Given this list of marker genes RAB31, BMP6, PGRMC1, MDFIC (NCBI Gene Id 29969), MX2, NEUROD1, FXYD6P3, SNX12, SPACA3, CBLB, GPR68, SOD1, ATPSCKMT, MIR424, METTL21C, RAB3D, CETP, SLC35F6, PKDCC, RAB4A, PAX8, RUBCN, TMEM97, GNB5, RIN3, SPG7, SLC31A2, RAP1GDS1, GCK, ANGPT1, NCBP2, CXCL11, TLR9, RAB27B, DNAJA1, SLC25A22, CD63, SV2B, TMEM38B, TOR1A, ABCA3, ARC, TUNAR, RGS2, PTPN11, CA2, MICAL1, BLK, ARHGDIA, NPY2R, UNC119, STX1B, HAP1, PDZK1 (NCBI Gene Id 96133), GAL (galanin and GMAP prepropeptide), SLC11A1, ENSA, UBE2G2, HTR1B, RANGAP1, SLC1A2, CLDN3, GHRHR (NCBI Gene Id 2692), CALM1, SLC7A5, NKAIN2, GRP, DOC2A, CELA2A, PLD1, HMGB1, APOA4, RHOQ, IL1RAPL1, RHBDF2, NR1H4, KCNJ16, KCNS2, TMEM38A, CD160, MIR186, UTRN, SYN1, ACTB, BCAP31, OPN3, FCN2, TNK2, VPS35, PPFIA2, PPP1CC, PTPN3, ANKRD13D, MDM2, PER2, FXYD2, PRAP1, RASL10B, ASIC2, IL12A, ATXN2, ZFYVE16, BDKRB1, SLC38A3, EDN3, PTPRC, GPC3, FERMT1, CPSF6, HLA-F, RPH3AL, KCNIP3 (NCBI Gene Id 30818), IL11, RAB3A, RFX3, MIR766, VAC14, ARF1, TPR, FMR1, ACE2, CTNND1, PFN2, SMPD3, ADRB2, MIR145, PRRT1, CEBPB, EDEM2, PTPRN, GHSR, ADTRP, SNAP25, RALA, NIPSNAP2, PPP3R2, TM7SF3, KCNA5, SYT13, CXCL9 (NCBI Gene Id 4283), ANKRD13A, IER3IP1, TNFSF11, INHBA, POMC, HMGA2, ORAI1, UCP2, AKAP8L, MIR495, NPY, LRPAP1, FUT11, HCRT, ZP3, RIMS4, MCTP2, KCNG1, SLN, LCN2, ADORA3, IRS1, SIRT4, SRC, NR1H3, KCNJ14, CABP1, PICK1, DENND10, NUMB, EP300, PARK7, ABCA8, SV2C, ATP9A, P2RY2, MYOM1, SORBS1, INHBB, HTT, ATP8A2, ABCA2, LILRA5, CHRM1, FFAR1, CASK, NOS2, GSTO1, CCN3 (cellular communication network factor 3), CACNG8, PCM1, TRPM5, ENY2, KCNA2 (potassium voltage-gated channel subfamily A member 2), DRD4, PLA2G5, PTPN1, MIR146A, RAC1, CACNA1B, CDH1, FLOT1, UNC13D, SERPINE2, PLPP4, GFAP, JUP, PTPRJ, TMEM132A, BORCS5, AGT, SLC8A1, TERT, SLC7A11, FRAT1, NFKB1, NKX2-5, SLC17A8, YJEFN3, MIR302A, IL4, DKK1, RAP1BL, CHP1, DHRS7C, RAP1GAP, MIR128-1, BCL2L1, SYT15, TREM2, XRCC4, VPS18, RAB9A, PCNT, DENND5B, CHMP3, MBTPS1, WNK3, TACR1, CASP3, SLC26A6, SCN2B, RAB3B, HCLS1, KHDRBS1, ZC3H12A, SELENOK, ERFE, MIR199B, SNCA, MAPK1, DMPK, ANK2, STAC2, TBC1D4, CYP19A1, NMU, THOC2, AP2A1, MUL1, ZNRF2, KIF5B, CCL19, VAMP2, LYN, CORO1A, CLDN2, ZNRF1, ABCA7, PHB2, TCAF2, DOC2B, RAB11B, GCLC, LILRA2, RUFY3, PRKAA1, SCFD1, APLN (apelin), DLL1, C1QTNF1, DCANP1, DISP3, SNAP91, GRIN3B, PTEN, JAK2, TRIM27, DERL2, CDH13, CALHM1, ICE1, TMED10, SMO, DDX39A, GABBR1, PACSIN2, SLC30A8, MPC2, SCRN1, CBLL1, CTSS, OAS2, IL1A, MIR183, ADCY8, MIR93, ACSL1, SIRT1, IPO5, SELENOS, USP46, CCL3, ASPH, MIR148A, WNK2, HAMP, STON1, AHNAK, STAC, RAN, PKIG, APOC1 (apolipoprotein C1), P2RY6, CNKSR3, MPV17L, P2RX1, FGA, ADCYAP1R1, CACNG2, SLC18A3, GNAS, FAM3D, CEP290, CCL21, STRIT1 (small transmembrane regulator of ion transport 1), KDM5B, C3, FCGR2A, SIVA1, ACHE, BMP2, ALOX12B, SSTR5, RCVRN, PKIA, PARD6A, PLAA, OAZ1, XCL1, SDC1, SCN4B, GAS1, SPHK1, GPM6B, PROM2, LGALS3, APELA, EMD, SRI, RIT2, ANKRD27, MAP2 (microtubule associated protein 2), STK11, HDAC3, ARL6IP1, CREB3, LACRT, CDH2, ABCA1, DPP6, TRIAP1, PHPT1, HADH, RAB5A, SERGEF, SCAMP5, SURF4, SELENON, TRPA1, APPL2, PPP3CB, EI24, SMPD1, TFR2, RSC1A1, REM1, RBM10, STXBP2, SGK2, RAB27A, FGF21 (NCBI Gene Id 26291), MIR133A1, CACNB3, G6PC2, JPH2, MIR20A, SPG11, C1QTNF12, HCAR2, KCNE2, MYB, SEPTIN4, CAMK2G, SCRIB, NF2, MIR199A1 (microRNA 199a-1), CPT1A, PRAM1, ERGIC3, GPD1L, ATP2C2, EFHB, RIC1, RAB11A, PLA2G1B, SLC16A1, FBXO45, SLC26A5, HCK, NNAT (neuronatin), POU4F2, SLC35D3, AZU1, BGLAP, PSMD9, TRIM58 (tripartite motif containing 58), RAB5B (NCBI Gene Id 5869), DYNC1H1, RIMS3, GIP, EHD1, ARL6IP5, GRIA1, DNM1L, VPS4A, NLGN2, SLAMF1, CD14 (NCBI Gene Id 929), FGF23, VEGFA, ABCA12, APOE, PFKM, LAMTOR1, AVP, AP2B1, PPP3R1, CERS1, NR1H2, NRP1, KLF15, CACNA2D1, SHH, SYT6, GNAO1, SNAPIN, STAP1, TRPV2, WNT5A, ABCG1, G6PD, MIR206, PDX1, CD2AP, WFS1, PTK2B, BAX, PACSIN1 (NCBI Gene Id 57564), SLC2A2, FCN1, LILRB1, PTPN23, C4B, CHRNB2, AKAP6, TGFB2, GAS6, LPAR1, MIR301B, SYT2, SLC25A31, RYR2, FABP5, MTMR2, MIR29B1, FCER1G, CCR2, PLA2G6, SMAD4, SELENOT, ANP32B, KCNIP4, DNAJC1, TMBIM6, PYCARD, GJA1, PDGFB, LYAR, SDHD, DYSF, GRK2, UBQLN1, IL2RG, WDR44, SYTL4, KIF20B (kinesin family member 20B), MIR30D, MYLK, PICALM, APOC2, CTTNBP2NL, GHRH, TMC1, KCNQ1, ECRG4, IL15RA, P2RX7, GRIN2A, AP2M1, RABEP1, MAGI2, RSPO1, TPCN2, RIOK2, TGM2, ATP2C1, GPR151, ADCYAP1 (adenylate cyclase activating polypeptide 1), TTC39B, MICU3, CFP, NOS3, C1QTNF3, FKBP1A, NEUROG1, TRH, TMEM53, RAB33B, IRS2, SCN3B, ACSL5, UMOD, CDK16, GNAI2, F2RL2, IL1B, TSC2, DLG4, PLD2, GSG1L, RIMS1, ITGAM, BAG3, SYT10, TCF7L2, ATP2A2, GCC2, FFAR2, ADORA2B, GSK3B, AAK1, MEF2A, GJA5, KCNB1, CD19, CNIH2, CADPS2, PGAP1, WDR41, HYAL3, ANK3, IL13, ADRA2C, GRM7, CCL2, OS9, TSPO, STXBP3 (syntaxin binding protein 3), SLC30A6, EPHA5, IFNG, REPIN1 (NCBI Gene Id 96712), PLLP, P2RY1, MIR758, RAB11FIP1, TAC1, PLA2G4A, OSBPL8, ITGB3, SARAF, MYRIP, PRKN, ABAT, KCNK9, SLC51B, CRHBP (NCBI Gene Id 1393), OCLN, KCNAB3, DBI, OSBP, CD300A, STC2, MIR185, SLC4A8, IL13RA2 (interleukin 13 receptor subunit alpha 2), LYPLAL1, MIR205, ACSL4 (NCBI Gene Id 4426), CD84, TSG101, RBP4, MIR144, PRNP, DNAJC6, CHMP6, AMIGO1, SVIP, PPIA, ERBB3, ASIC1, CD36, CDH3, LIF, TRPV6 (NCBI Gene Id 55503), SNX4, ABCC8, SYBU, NSF, HIP1R, ATP1B2, CHRNA6, PRKCG, CLU, BRSK2, HEPH, MIR107, ATG5, SLC12A2, AFG3L2, CCDC32, CHGA, RHBDD1, ARPC3, COLEC10, HRC, TULP1, TRPM4, PDE4B, SNCAIP, FGR, FGF20, FERRY3, MAP2K1, SIRT7, TGFB1, MIR129-1, PACSIN3, PID1, SLC43A2, ARHGAP1, CBL, BMP8A, MIR143, TRPV3, MIR30C1, VAMP8, CARTPT, HK2, GAPVD1, USP7, CD4, ARRB2, PPP1R12A, BMAL1, OPHN1, CLDN19, PASK, RAB5C, ATP2B4, SYT8, F2RL3, XBP1, PPP3CA, TTN, CRY1, JAGN1, SOX11, PIK3CG, SNX6, TFF2, LRRTM2, ARFIP1, IDH2, SLC30A3, NF1, SDC4, GGCX, IL16, CD151, ITSN1, KCNS1, EFNB2, MIDN, ZPR1, ADA, GIT1, CACNG4, FCGR1A, FKBP1B, FXYD1, CHRNA3, CYP4F2, GNB2, PTCH1, RAB25, S100A8, ERP29, ABCG4 (NCBI Gene Id 64137), EDNRA, ZBED6, NOTCH1, BTBD9, ASPSCR1, IL6, FEZ1, MEF2C, PRKCD, HIP1, SYT17, B2M, AKT1, STXBP4, AAAS, SYT5, LRAT, KCNIP2, DMAP1, COLEC11, CLASP1, STC1, P2RY12, RAB37, KCNF1, PLN, MIB1, NUP214, TESC, LRRK2, BAD, SYK, BEST1, RGCC, CTDSPL2, NR1D1, NKX6-1, AACS, ANXA1, LDLRAP1, CRH, SEPTIN2, SDCBP, PTPRN2, GDNF, MIR133B (microRNA 133b), SLMAP, CTNNB1, OR51E2, ARHGEF5, TBC1D5, SPX, SERPINE1, CACNG5, SCN1B, SEC24A, SLC25A5, RXRA, FXYD4, ADAM9, HOMER3, APOA2, RFX6, NGF, YOD1, GPER1, USH1G, PRKCA, CALCA, OAZ2, CYP4A11, P2RX4, BSG, AQP1, NDFIP1, GATA1, SYT3, CHP2, PCK2 (NCBI Gene Id 5106), LRRC26, NPFF, FXYD7, RAB21, SGK1, GLI3, CFTR, PLCG2, DRD2 (dopamine receptor D2), POFUT2, STX18, ANO6, BEST3, PFKFB2, CALM2, SNF8, PPM1A, SERP1, ATP1A2, GPLD1, STK39, ANXA13, FOXL2, CDK1 (cyclin dependent kinase 1), NKAIN1, NEDD4, UCN, CD47, UBR5, NECAB2, TMEM30B, COX17, MIR26A1, FCGR2B, SLC43A1, UBQLN2 (NCBI Gene Id 29978), SIRPB1, CRBN, APP, FRMD4A, RIPOR1, B3GAT3, KCNJ3, NUMA1, DERL3, CEP131 (centrosomal protein 131), ILDR1, SFTPD, MIR130B, HOMER1, LRP5, MIR223, ALOX5, CCL5, NPR1, CLIP3, PXK, NHERF1, CACNB4 (calcium voltage-gated channel auxiliary subunit beta 4), FGF12, JPH3, CACNG3, LPAR3, CLDN10, NDEL1, TUB, ITGB2, SPHK2 (sphingosine kinase 2), ABCB4, IL12B, PRKD1, CACNG1, CAMK1, CWH43, P2RX3, HSP90AA1, TGFB3, NSUN2, TRPC3, CXCL10, F2R, PRKAR1A (protein kinase cAMP-dependent type I regulatory subunit alpha), EPO, MIR212, TCIRG1, FIS1, PIK3R1, SCARB1, EPB41, LEP, PRRT2, MYO18A (NCBI Gene Id 9799), ATP1B3, OXCT1, KCNJ5, VEGFC, EHD4, NEDD4L, INPP5F, HES1, SAR1B, PDE8B (NCBI Gene Id 8622), UCN3, COMMD1, SIK1, VPS4B, MLXIPL, OSR1, MKLN1, CACNB2, DHX9, CLEC7A, RAB7A, TNFRSF1A, REEP6, PRSS8 (serine protease 8), MIR208B, SCP2, HTR2C, SEPTIN8, KCNJ6, NMB, MIF, CLASP2 (cytoplasmic linker associated protein 2), SGIP1, YWHAH (NCBI Gene Id 7533), CAV3, CACNA1F, SMAP1, MIR1-1, ADORA2A, AVPR1A, MBL2, PPARA, MMP9, TMSB4X, APOD, OPRM1, AHI1, GRM2, ZNF205, RHBDF1, KCNJ4 (NCBI Gene Id 3761), VTN, OXT, CACNG7, KCNAB1, WLS, RBM4, HGS, AXL, MIR499A, CHMP2A (NCBI Gene Id 27243), EHD2, EPM2A, GDF9 (NCBI Gene Id 2661), KCNMB4 (NCBI Gene Id 27345), CDC42, HTR1A, AIMP1, PLA2G4E, ATF4, UBASH3B, NEU3, SH3GL3, KCNC2, MIR27A, KCNC1 (potassium voltage-gated channel subfamily C member 1), FHL1, CYP51A1, NKAIN3, MIR34B, PLCB1, STXBP6, LPCAT3, LCP1, STIM2, THY1, LYPLA1, CA7, DAB2, FGFR1, CPLX2, SFN, BICD1, STOM, CAMK2D, PPT1, AP2S1, KCNN2, INS, NPPA, CACNA1D, GRIN1, BSN, GHRL (NCBI Gene Id 51738), DMD, SMCR8, PCSK9, KLRC2 (killer cell lectin like receptor C2), IGF1, WNT7A, NDFIP2, MIR448, KRT20 (NCBI Gene Id 54474), TLR2, EFNA5, HMGCR, TM9SF4, OXSR1, MIR9-1 (NCBI Gene Id 407046), SCIN, EDN1, BOK, TMEM30A, ROCK1, ABL1, BCR, AHCYL1, ALOX15, AZIN1, STAC3, NPY5R, APOA5, LEPR, MIR328, KCNJ8, FCGR1BP, MAP2K2 (mitogen-activated protein kinase kinase 2), SCT, GPR35, PINK1, MINK1, OPRK1 (NCBI Gene Id 4986), ITLN1, CRYZL2P-SEC16B, ERLEC1, CORIN, OAZ3, CD38, WNT3A, HSPA8, SUSD4, PLTP, CALM3, MIR34A, WWC1, EXPH5, ARAP1, GRIPAP1, CHRNB4, ACVR1C, ACTN2, RUFY2, ISCU, GRM6, ITGAV, EZR, P2RX5, PLCG1, KCNJ2, FASLG, UQCC2, F2, FFAR4, WNK4, SNTA1, DLG1, ITGA2, NADK, XPO1, RAB29, TCAF1, FGG, VDAC1, PSEN2, ERC2, PON1, IL15, EPHA3, BMP2K, FABP3, REST, KEL, PPARG, OTOF, P2RX2, RAP1A, NTF3, YWHAE, LRP1, KCNS3, AKAP7, BARD1, DRD1, TNFRSF11A, CLN3, GIPR, MIR873, TFAP2B, NEGR1, SETD2, BAIAP3, RAB4B, DNAJC5, RHBDD3, SLC25A4, TAMALIN, FRAT2, ISL1, ZDHHC2, CD74, RUFY4, CD177, GAB2, STXBP1, SEPTIN1, AZIN2, SLC38A2, FOXO1, STIM1, BCL2, MTNR1B, UBR3, TARDBP, RAPGEF4, LRRTM1, ECT2, TBC1D20, ADORA1, APBB3, FCRL3, NEO1, APOC3, KCNJ15, FURIN, LRSAM1, PLA2G10, CSK, SAA1, RAB23, FCN3, CPLX1, BMP4, PRKG1, EEF2K, TMEM14A, ITGB1, PDCD6IP, SLC34A1, TRPC6, HHEX, CXCL12 (C-X-C motif chemokine ligand 12), XPO4, WDR54, RNF139, SLC17A7, GSTM2, PTGES (prostaglandin E synthase), FYN, ZIC1, ANXA2 (NCBI Gene Id 792), SMAD3, SNX3, CYBA, SP100 (NCBI Gene Id 6672), MIR208A, RUFY1, TMX1, VAMP7, REEP2, CALY, GALR2, NEFH (NCBI Gene Id 4744), PREPL, SNX17, LIPG, MIR92B, CPLX4, ATP13A2 (NCBI Gene Id 63919), SUFU, OSM, ZFAND1, LAMP1, SYT4, TNNC1, TXN, OPRD1, RGS4, DGKD, SLC25A27, NAXE, PEA15 (NCBI Gene Id 8682), HLA-DRB1, EIPR1, SIDT2, KCNG4, PPID, STIMATE, ARHGAP44, VPS28, CD22, MLC1, CREB1, LIME1, PKD2, KCNJ9, MCU, VAMP3, MIR508 (microRNA 508), TRIB3, SYT7, DYNC1LI1, SIRT6, PLA2R1, ABCB1, DGKQ, C4A, PDPK1, RDX (NCBI Gene Id 5962), ACTG1, CDK5R2, CDKN2A, TF, CSPG5, PLA2G3, USE1, PRELID1, MIR19B1, TRDN, RNASEL, TENM1, RNF220, KMO, PRKAG2, YWHAB, ARF6, EPPIN, FUT10, SNX9, AP1G1, SH3TC2, GH1, P3H1, CNN2 (NCBI Gene Id 1265), SORL1, CD300LF, RAB3GAP1, WNK1, FCGR2C, GSK3A, PER1, LETMD1, KLF7, TRIM28, FXYD6, SCN10A, KCNE5, RAB11FIP5, HNF4A, ADCY5, TTC21B, TMF1, GCG, APBB1, RIMS2, CNST, GATA2, GABRE, UFM1, ACTN4, CEACAM1, CNIH3, TSPAN13, ADRA2B, KCNN4, CDK5, CAMK1D, GOLPH3, GNA11, FXYD3, GALR1, CASQ2, FZD9, PFKL, CHRM3, PTH, HPCA, GOLPH3L, IFI27 (interferon alpha inducible protein 27), RAB2B, SNX33, PTGER3, PDGFRB, AKT2, JPH4, MIR103A1, KCNAB2, MSN, PPARD, NR4A3, KCNJ1, PIM3, WASL, OSTN, CLOCK, RINT1, PRKG2, CRY2, TOR2A, BPIFA1, PRKACA, CCR7, DYNLT2B, CHCHD10, RAB26, YIPF5, NFKBIA, PPIF (NCBI Gene Id 10105), SOX4, MIR181B1, SLC6A4 (NCBI Gene Id 6532), SIRPG, ARHGAP8, FGF13, RABGEF1, FER1L5, CHRNA4, SNCG, FES, INPP5K, GPR143, MCHR1, MIR17, DIAPH1, PDCD10, SYNJ2BP, FAM76B, MAP1B, TSPOAP1, NKAIN4, NKX3-1, SLC30A1, PRTN3, ICA1L, ACAA2, DTNBP1, HIF1A (NCBI Gene Id 3091), CHD7, MAPK3, FLNA, FOXA2, MRLN, MIR33A, AKAP5 (NCBI Gene Id 9495), CALR, SPAG5 (NCBI Gene Id 10615), ATP8A1, NFE2L2, CASQ1, GRIN2B, CACNB1, NUP58, FFAR3, PTPN6, PIP4P2, PLS3, ATP5IF1, TIFAB, NOS1AP, OSBPL6, MYH10, PTX3, SPI1, KCNIP1, MCUB, NPVF, LMAN2, KCNG2, STXBP5 (syntaxin binding protein 5, NCBI Gene Id 134957), ATP2B1, ARFGAP1, ANKFY1, NDRG4 (NDRG family member 4), GPR27, ANKRD1, KCNK16, CD33, MIR613, CCL4, KCNJ12, PPM1F, NPSR1, PTPRM, VAMP4, SEMG1, TNFRSF1B, GNAI1, SYNGR3, SYT1, NPPB (natriuretic peptide B), ITPR1, ALKBH5, SCG5, NDUFAF2, CLIC2, SPP1, CLTCL1, SLC9B2, NUS1, PRR5L, PLK3, PSEN1, ATP8B1, PRKCI, NCDN, CAB39, ZDHHC7, EEPD1, TRPC1, IL4R, ANXA2P2, ENPP1, HFE, IL2RB, MCTP1, EGF, LRRC52, CPLANE2, NTSR1, REEP5, NR0B2, CAMK2A, DAPK1, UHMK1, HOMER2, GRB10, ARPP19, DPH3 (NCBI Gene Id 285381), APOA1, AGTR1, RAB8B, RETN, STX1A, UBAC2 (NCBI Gene Id 94902), KCNG3, RAB11FIP3, CLTRN, PKP2, CAV1, EFCAB7, PIK3CB, ABCA5, DPP10, NLRP6, APLNR, GRIN2C, GOPC, BTK, MYO6, CX3CL1, PRP4K, MYOF, DVL1, CACNA1C, GPR158, PRKCE, YWHAQ, KCNJ10, FGB, CEMIP, BRAF (B-Raf proto-oncogene, serine/threonine kinase), THBS1, BAK1, SEC16B, RAP1B, DYNLL1, JPH1, CNTN1, UNC13B, BVES, KCNH2, STAT3, LYSET, AVPR1B (arginine vasopressin receptor 1B), TRAT1, DRD3, LRRC55, RAB3C, CD81, CXCR3, CCKAR, PTPN14, VPS11, CD200, NLGN1, MERTK, PRL (prolactin), ADRA2A, MIR27B, SLC8B1, KCNE1, MLLT6, UBE2J1, MIR200C, PRKAR1B, ADIPOQ, CADPS (calcium dependent secretion activator), ARV1, STX4, CRYAB, TNF, GPS2, KCNJ11, S100A10, FPR2 (formyl peptide receptor 2), CRHR1, RAPGEF3, TLR4, STAM, SREBF1, INSIG1, TACR2, RTN2, DNAJC13, FBXL20, FGF10, SESTD1, YRDC, ANO1, RANGRF, LRRC8A (NCBI Gene Id 56262), ABL2 (NCBI Gene Id 27), CES1, RBM22, C2CD5, NOS1, KCNJ18, GRIK5, SYT9, SEPTIN5, MIR451A, ICA1, F2RL1, VSNL1, ATG3, INSR, KCNE3, ATAD1 (NCBI Gene Id 84896), ANKRD13B, SH3GL2, C2CD2L, TMC2, STON2, INHA, ANG, LGI3, MS4A1, CCR1, CACNG6, CREBL2, FXYD5, ADAM8, ABCC9, SCN5A, CAMK2B, SIRT3, PLSCR1, PNKD, MIR21, SPINK1, ABCB11, SLC25A6, SUMO1, FOXF1, C2, SEC24B, HYAL2, MIR33B, MIR24-1, EDEM1, NEAT1, PDE4D, MTMR4, RPH3A, SELE (selectin E), BIN1, GRAMD2A, CRACR2A, ABCA13, ZDHHC8, APPL1, RACK1, MIR192, IWS1, VMP1, REN, KCNJ13, PML, ACSL3 (NCBI Gene Id 55484), RAB8A, SHISA7, SREBF2, ARRB1, MYLK2, RSAD2, ATP1A1, C9orf72, PIM1, ATP4A, NUP153, CAPN10, SYT12, TMEM102, SPTBN4, NRDE2 (NRDE-2, necessary for RNA interference, domain containing), LILRB2, BET1L, CAPN3, MIR326, CASR, ATP2A1, PIK3R2, RAC2, SYT11, LRRC38, GREM1, GLUD1, SFRP4 (NCBI Gene Id 6424), HSPA1A, LGALS9, RAB15, GPRC6A, HTR2A, H1-1, USP6, EPRS1, GRIN2D, PPP3CC, RGS9, NCKAP1L, TRIM46 (tripartite motif containing 46), NRG1, SIRPA, FGF19, MIR210, PCLO, MIR19A, WWP2, ATP1B1, DOCK2, CRYAA, MAPK14, YES1, IER3, KCNRG (potassium channel regulator), PRKCB, ADGRE2, GNAZ, MYBPC3, AHSG, CPLX3, CBARP, MAVS, here is a description of the gene set: Human Gene Set: GOBP_REGULATION_OF_TRANSPORT Any process that modulates the frequency, rate or extent of the directed movement of substances (such as macromolecules, small molecules, ions) into, out of or within a cell, or between cells, by means of some agent such as a transporter or pore. species: Homo sapiens